The following is a description of a gene set: The chemical reactions and pathways involving dolichols, any 2,3-dihydropolyprenol derived from four or more linked isoprene units. Human Gene Set: GOBP_DOLICHOL_METABOLIC_PROCESS species: Homo sapiens, and this is the list of marker genes: DPM1, DPM2, SRD5A3, DHDDS, DPM3, DHRSX, DOLK, NUS1 (NCBI Gene Id 116150)